The following is a description of a gene set: A protein complex that is capable of associating with DNA by direct binding, or via other DNA-binding proteins or complexes, and regulating transcription. Human Gene Set: GOCC_TRANSCRIPTION_REGULATOR_COMPLEX species: Homo sapiens, and this is the list of marker genes: MED4, STAT3, SOX8, TAF1L, SMAD7, SKI, NFYB, BATF3, STAT2, BRF1, TRIM28, ARNT, MMS19, TBX15, SATB2, MED21, GPS2, MAF, ERCC3, GFI1, FOSL1, SNAI3, PTF1A, ENY2, TBPL1, LIN54, TLE3, CEBPG, SUPT3H, SIX4, AJUBA, ATF6B, TAF11L13, HMGB1, MDM4 (MDM4 regulator of p53), ZNF541, ZNF350, CREB3, HMGA1, TAF7L, GSC (NCBI Gene Id 2927), TAL1, TLE4, STAT4, TCF15, DDIT3, HEY2, NPAS2, MED1, MED31, NFATC1, HOXB9, CBFB, TAF2, MBD2, CEBPB, NEUROD1, GATA2, DR1, RUNX1, ATXN7, TAF5L, NR6A1, ARID5A, TCF21, MED18, GLI3, YAP1, GTF3C5 (general transcription factor IIIC subunit 5), SIX6, BSX, NFE2L2, RFX5, KAT2A, RLIM, TAF1B, GTF2H5, HOXD12, CREM, DDX20, RBBP4, GMNN, LDB2, TAF3, NFKB1, CTBP2, HOXA9, TAF11L11, FOSL2, THRB, SCX, STAT6, HOXA10, NCOA6, SKIL, H1-0, MED22, SPI1, PRDM16, SMAD2, SMAD1, TCF7L2, POU2F3, SPEN, RBL2, CORO2A, GTF2E1, MYOG, NKX2-5, CEBPZ, ADNP, ETV3, PBX3 (PBX homeobox 3), MED30, TEAD4, NFATC3, GTF2E2, GTF2F1, MYF5, SNAPC1, TAF11L12, YWHAB, SP1 (Sp1 transcription factor), LHX1, JDP2, RBM14, CEBPA, HES6, SUB1, CBX5, SMAD5, MED26, FOS, ANXA2, HAX1, NFE2L3, EPAS1, POU4F1, BMAL1, GATA6, MEIS1, DEAF1, TFEB, ZFPM1, TFDP3, CDK7 (cyclin dependent kinase 7), PITX2, STAT1, TCF4 (NCBI Gene Id 6925), TAF13 (TATA-box binding protein associated factor 13), PBX2, LMO4, ASCL2, TLE2, ESR1, ATF7IP, POU2F1, PASD1, CCNH, BCL9, KAT5, TAF11, TAF4B, TBX5, LIN9, TAF9, SNAPC4, RB1, STAT5A, KLF4, MTA1, TAF11L9, MED27, SOX2, NHLH2, MYF6, POU4F2, HDAC3, TBX2, TAF6, MED9, YY2, CTNNBIP1, SIX3, ASCL4, TEAD2, TAF9B, GFI1B, RELB, NR5A2, MED25, BIN1, N4BP2L2, TRRAP, XBP1, TFAP2D, NAA15, TCF7L1 (NCBI Gene Id 83439), SIN3A, ANHX, GATA4, JAZF1, SFPQ, NCOA1, SOX9, MIER1, HOXB13, AATF, SNAPC3, GATAD2B, FOXF1, STAT5B, JUNB, SP3 (NCBI Gene Id 6670), WTIP, PDLIM1, SNF8, SKOR2 (NCBI Gene Id 652991), CHD4, CREB1, MAFF, PAAF1, PER2, SMAD9, E2F6, MTA2, ELANE, E2F4, TAF12, RXRG, RBBP8, GTF3C4, SIX1, MED6, TCF12, MBD3, CREG1, GATAD2A, TLE7, TAF5, E2F1, TAF11L7, HDAC2, MIDEAS, MAFK, CTNNB1, SDR16C5, ASCL5, PPARG, ERCC2, BATF, TCF3, POU2AF1, HYAL2, FOXH1 (NCBI Gene Id 8928), MED15, E2F3, HNRNPAB, LIMD1, BMAL2, MED20, E2F2, MED19, POU5F1, ONECUT3, RUNX2, BORCS8-MEF2B, SMAD6, BDP1, PITX1, TBP, MYOD1, MEF2A, TRERF1, E2F8, NCOR1, HDAC1, SOX4, NCOR2, TAF1D, RFX3, GTF2A2, MED14, DACH2, TEAD1, CRY2, MED28, TLE6, TCEA1, MED7, BRF2, CHD5, NFATC2, FOXF2, ATF7, SMAD4, SIX2, FOXE3, MAX, MED11, HOXA11, TFAP4, TP53, ATF1, CEBPD, GTF2H1, HAND2, TAF1A, MED16, NFYA, HIF1A, TAF11L14, CBX3, NAA16, CCND1, TAF8, SOX15, GTF2F2, NKX2-1, TBX18, ISL1, RUNX3, TBL1X, NR1H2, LDB1, GTF2A1L, LMO2 (LIM domain only 2), NPAS4, RCOR3, NR4A3, NR1H4, POU3F2, C1D, GTF3C6, E2F7, NCOA2, MXI1 (MAX interactor 1, dimerization protein), TCF7, PROP1, GTF3C3, USP22, HDAC9, DRAP1, CEBPE, KDM1A, ARNT2, PRDM10, TAF4, TAF7, MED23, RCOR2, MAFB, GTF2H2C_2, GATA1, SOX18, HLF, PBX1, GTF2H2C, BACH1, NR1I2, LEF1, TAF10, PYGO2, JUND, CREBBP, E2F5, RCOR1, MNAT1, NFIL3, USF1, CHD3, GTF3C1, NFYC, CDK2AP2, HAND1, XRCC6, RBPJL, RFXAP, ALX4, ATF2, ATF6, HOXC9, PARP1, MYC, NFAT5, LBX1, MDM2, IVNS1ABP, FIGLA, HOXD10, POLR1G, CDK2, MLXIPL, FOXO3, CDX2, PTOV1, NR1H3, ZFP42, MED8, GEMIN5, ATF3 (activating transcription factor 3), TBL1XR1, YY1, INSM2, MED24, GTF3C2, TFDP2, MED10, SMAD3, SSBP3, POU3F1, TAF11L3, TAF11L2, SOX14, ATF5, RBBP7, NR4A1, TAF11L4, RBL1, BCL9L, TAF11L8, HDGF, DEPDC1, ASCC1, TAF11L6, SOX17, ABT1, SKOR1, PKNOX1 (NCBI Gene Id 5316), GTF2H3, JUN, MEF2B, GTF2H2, RBPJ, ZBTB16, DBP (NCBI Gene Id 1628), ZNF224, RXRB, HNRNPU, DMBX1, FLYWCH1, HDAC4, GCM1, TAF6L, PHF12, RARG, CREBZF, ALX1, AHR, TAF11L10, AKIRIN2, BARX2, S100A10, BATF2, HIPK2, ATXN7L3, MSX2, ZFHX3, BEX1, NR5A1, CLOCK, RARA, KLF5, MSX1, WWTR1, NR2E3, HLTF, RXRA, CRX, NFE2, ASCL3, MYB, PBXIP1, LIN52, PMF1, LHX3, CDK4, ATF7IP2, REST, RIOX2, MEN1, MTA3, SIX5, ATF4, LIN37, VDR, TADA3, TFDP1, MED17, TAF1C, ARID4A, NFATC4, RFXANK, THRA, IRF9, MAFG, PUS1, RELA, ASCL1, DACH1, GTF2B, TLE1, BACH2, ANKRD1, TAF1, PRKDC, MXD1, GTF2H4, MED29, HNF1B, GTF2A1, HELT, CDK2AP1, NR4A2 (nuclear receptor subfamily 4 group A member 2), MXD3, ING2, CTBP1, TEAD3, EP300, NONO, INSM1, HCLS1, WWOX